Given this list of marker genes Grin2c, Ptprf, Lrfn3, Epb41l2, Il1rapl1, Dlg4, Nrxn3, Dlg1 (NCBI Gene Id 320792), Nrxn1, Il1rap, Dlg2, Rtn3, Grm1, Slitrk1, Slitrk4, Ppfia4, Lrrc4b, Epb41l5, Shank1, Epb41, Nlgn4l, Ppfibp1, Slitrk6, Ppfia2, Nlgn1, Flot2, Ptprd, Lrrtm1, Nlgn3, Slitrk3, Gria3 (NCBI Gene Id 73036), Slitrk2, Homer1, Dlgap3, Grin2d, Lrrtm4, Dlgap4, Epb41l3, Nlgn2, Lrfn4, Dlg3, Sorbs2 (sorbin and SH3 domain containing 2), Ppfibp2, Flot1 (NCBI Gene Id 14251), Il1rapl2, Slitrk5, Ntrk3, Nrxn2, Lrfn1, Grin1, Lrrtm3, Lrfn2, Dlgap2, Grm5, Lrrtm2, Dlgap1, Ptprs, Cask, Gria4, Homer2, Ppfia1, Shank3, Gria1, Homer3, Ppfia3, Grin2a, here is a description of the gene set: species: Mus musculus Protein-protein interactions at synapses Mouse Gene Set: REACTOME_PROTEIN_PROTEIN_INTERACTIONS_AT_SYNAPSES